The following is a description of a gene set: Human Gene Set: GSE43955_TH0_VS_TGFB_IL6_TH17_ACT_CD4_TCELL_42H_UP Despite their enormous importance, the molecular circuits that control the differentiation of Th17 cells remain largely unknown. Recent studies have reconstructed regulatory networks in mammalian cells, but have focused on short-term responses and relied on perturbation approaches that cannot be applied to primary T cells. Here, we develop a systematic strategy – combining transcriptional profiling at high temporal resolution, novel computational algorithms, and innovative nanowire-based tools for performing gene perturbations in primary T cells – to derive and experimentally validate a temporal model of the dynamic regulatory network that controls Th17 differentiation. The network is arranged into two self-reinforcing and mutually antagonistic modules that either suppress or promote Th17 differentiation. The two modules contain 12 novel regulators with no previous implication in Th17 differentiation, which may be essential to maintain the appropriate balance of Th17 and other CD4+ T cell subsets. Overall, our study identifies and validates 39 regulatory factors that are embedded within a comprehensive temporal network and identifies novel drug targets and organizational principles for the differentiation of Th17 cells. Genes up-regulated in CD4 T helper cells (42h): Th0 versus TGFB1 and IL6. studied in species Homo sapiens from publication Yosef N, Shalek AK, Gaublomme JT, Jin H, Lee Y, Awasthi A, Wu C, Karwacz K, Xiao S, Jorgolli M, Gennert D, Satija R, Shakya A, Lu DY, Trombetta JJ, Pillai MR, Ratcliffe PJ, Coleman ML, Bix M, Tantin D, Park H, Kuchroo VK, Regev A (PMID 23467089), and this is the list of marker genes: AOPEP, KCNK3, TM9SF1, ASF1A, RASSF2, SART1, HSPA1B, ESRP1, HDC, SLC25A19, PMP22, MRPS28, BCL7C, PHTF1 (putative homeodomain transcription factor 1), ARHGAP39, KCNN4, SLC35B2, CYTIP, ARPP19, ISG15, TOMM70, SAP30BP, BCAR1, ISOC1, SMC6, STARD3, ACKR2, PDZD11, MYBBP1A, SEMA4D, NMRK1, ELP3, NSG2 (neuronal vesicle trafficking associated 2), CDH5 (NCBI Gene Id 1003), RCAN1, ATN1, SSU72, SPSB1, CXXC5, KIF1B, CENPL, CST8, EPHA6 (EPH receptor A6), IFIT3, CYP4A22, ANKRD13C, PLEKHB2, AUP1, TP53BP1, BOP1, PSMB8, CAPN2, RAB5B (NCBI Gene Id 5869), VPS26B, RRAGC, CACNB3, TPGS2, MEIS2 (NCBI Gene Id 56908), PEBP1, EVI5, CARD19, RPL28, IL1RL1, EVL, DAXX, TOR3A, ASF1B, TRAIP, PRRC1, SHBG, RAB3A, CXCL2, NDE1, CDK2AP1, MNS1, TTC3, KIF1C, RPP21, TAF6, PIAS1, SH2B3, NSMCE3, KLF12, INSR, DOCK7, NELL2, OLR1, STXBP1, MOB1A, ALOX12, AHNAK, SERPINB5, MRPS17, EVX1, GALNT3, KLF2 (KLF transcription factor 2), GDI1, IRF1, IFIT1B, RTN4, PRDX1, RBM42, FBXL15, GSPT1, LAP3, OTULINL, PDE8A, CYP1B1, PLAUR, PIGU, ZNF574, RIOX2, UBE2G1, MX1, CLIC3, EFNB2, GLUD1, MRPL34, CSRP3, PEX7, RNH1, DIDO1, PRDX6, TRIM25, TXNL1, C6orf62, MAPK14, CES3, FERMT2, NUP54, CSNK1A1 (NCBI Gene Id 55416), NAA38, AP3M1, ATP5F1C, DDHD2, SUN2, RABGGTA, WASHC2A, ADAR, PFKFB2, RSAD2, CMTR1 (NCBI Gene Id 23070), P2RY1, PRLR, CYTH3, DAB1 (DAB adaptor protein 1), ST6GALNAC4 (NCBI Gene Id 27090), SIGMAR1, TAP1, NACC2, IL15RA, CAV1 (caveolin 1), ICAM1, ALCAM, TRAFD1, C1R, OST4, LSM14A, PLAT, PURA, VPREB3, MAIP1, EIF3D (eukaryotic translation initiation factor 3 subunit D), GRK5, CYBA, RRH, IL1R2, HMGCR, HGFAC (HGF activator), IRF9, MFSD14B, ADISSP, GM2A, NDUFA9, TSEN15, ST8SIA4, TTL, LDLR, GABARAPL1, LGALS3BP, ABCB1, SUGT1, LSS, DEAF1, UCHL1, RCVRN, PTGES3, IRF7, CKM (NCBI Gene Id 95741), PCGF5, MRPL58, BRI3, MACIR, PPP2R5A, DPP3, RPS5, ACADM, MX2, MBP, GPN3